Given this list of marker genes LRP5, BAX, LEF1, SPI1, BAK1, here is a description of the gene set: Any apoptotic process that is involved in blood vessel morphogenesis. Human Gene Set: GOBP_APOPTOTIC_PROCESS_INVOLVED_IN_BLOOD_VESSEL_MORPHOGENESIS species: Homo sapiens